Given this list of marker genes Trp53 (NCBI Gene Id 22059), Htra2, Htr2a, Mtrnr2l7, Gcg, Hspd1, Trp53bp2, Bcl2l1, Casp8, Dffa, Ripk1, Ndufa13 (NCBI Gene Id 67184), Sirt2, Dlc1, Ptgis, Fzd3, Cxcr3, Fadd, Fap, Cidea, Bcl10, Tradd, Bok, Rbm10, Zc3h12a, Tnfrsf1a (NCBI Gene Id 21937), here is a description of the gene set: Mouse Gene Set: GOBP_REGULATION_OF_EXECUTION_PHASE_OF_APOPTOSIS species: Mus musculus Any process that modulates the frequency, rate or extent of execution phase of apoptosis.